The following is a description of a gene set: Genes predicted to be targets of miRBase v22 microRNA mmu_miR_1906 in miRDB v6.0 with MirTarget v4 prediction scores > 80 (high confidence targets). studied in species Mus musculus Mouse Gene Set: MIR_1906 from publication Chen Y, Wang X (PMID 31504780), and this is the list of marker genes: Apba1, Tacc1, Slc15a4, Tll1 (NCBI Gene Id 21892), Pou3f3 (POU domain, class 3, transcription factor 3), Slc22a23, Ino80d, Phf5a (PHD finger protein 5A), Wap, Zcchc2, Wdtc1 (NCBI Gene Id 277762), Fkbp5, Cdc42, Ppp1r3f, Vipr2, Dennd6a, Nf2, Eif4b, Tspan9, Chic1, Dpp9, Nacc2, Gpat4, Znrf3, Ralgps1, Ptpn4, Tmem241, Esrrg, Pappa, Ccnyl1, Gns, Zfp609, Ptprj, Cacna2d1, Adgrl2, Aoc3, Ssx2ip, Rasgef1b, Znrf2, Luzp1, Cd8b1 (CD8 subunit beta 1), Myt1l, Socs7, Slc45a4, Exoc6b, Pi15, Idh3a, Fam168b, Faf2, Ppm1k, Ankrd13d, Nphs2, Sbno1, Map3k4, Cobll1, Tcaim, Dmtn, Cc2d1b (coiled-coil and C2 domain containing 1B), Lurap1l, Lhfpl4, Mthfd1l, Zfp687, Wnk1, Strbp, Arel1, Zfp592, Ppp1r2, Peli3, Ankfy1, Fbxo9, Vegfa, P2rx6, Kif1b, Kmt5a, Ezh1, Nuak2, Ubxn7, Dcaf12l1, Crtac1, Csnk1g3, Plxna2, Tmem87a, Gpc6, Pak2 (p21 (RAC1) activated kinase 2), Plcxd2, Smg5, Pdlim1, Dhdds, Abcf1, Zdhhc8, Ccser2, Hdgfl3, Pak3, Clic5, Tnrc6b, Pacsin2, Drd1 (dopamine receptor D1), Hcfc1, Dhx58, Cpeb2, Zbtb43, Tmem41a, Otx1, Cab39, Ppp2r5a, Klf4, Krt90, Crocc2, Ciita, Litaf, Nufip2, Nktr, Cdk17, Zbtb10, Prr14l, Osbpl6, Rab1b, Cadps2, Hira, Kif21b (NCBI Gene Id 320287), Lrrfip2, Pola1, Actg1, Has2, Dcaf7, Pfpl, Ikbkb, Pkdcc, Ubfd1, Bmpr1a, Map3k7, Brsk2, Ccser1, Clip1, Tfap2a, Meox2, Scaf8, Icmt, Ppp4r3b, Spsb4, Apln, Spg21, Arhgap5, Kcnh8, Frmpd1, Zhx1, Swsap1, Tsbp1, Fam98a, Ubap1, Slc4a8, Cacna1c, Akap11, Cpeb3, Esrra, Dpy19l3, Ranbp3 (RAN binding protein 3, NCBI Gene Id 71810), Twf1, Bag5, Pdia6, Adgrb3, Cd109, Exd2, Cfap45, Ccnjl, Ap2a1, Sun2, Fbxo21, Ahcyl2, Nav1, Cdadc1, Jade2, Sec24b, Scn2a, Slitrk1, D2hgdh, Klc1, Sdf2, Sptan1, Nr6a1, Fkbp1a, Dtnb, Acsl1, Sppl2b, Pi4k2a, Jakmip2, Safb2 (scaffold attachment factor B2), Agfg1, Pnpla6, Tbkbp1, Cluh, Sting1, Chd2, 4930503E14Rik, Plpp1, Klf14, Eif4g2, Il17d, Zfp882, Fstl4, Klhl18, Armc1, Mmp19 (NCBI Gene Id 58223), Trmt61a, Hcls1, Med1, Tmem150a, Mpc1, Ube2v1, Ppp6r2, Rapgefl1, Armcx6 (armadillo repeat containing, X-linked 6), Rnf38, Fsd1, Egln2, Lamc1, Ssrp1, Elavl3, Crtc3, Chd1, Naa20, Tmem245, Angel1, Pank2, Dolpp1, Cep85, Eif4a2, Tmem98, Mllt10, Rc3h1, Dgcr2, Tigd5, Selenoi, Adissp, Zyx, Raf1, Gga3, Cbx6, Ddi2, Cdk6, Dstn, Smad3, Treml1, Kif5b, Gm2663, Vav2, Kpna4, Thbs2, Synrg, Ccdc38, Fibcd1, Tab2, Itpr1, Rab7b, Adap1, Gm5622, Syna, Rab4b, Trmt44, Atg13, Gle1, Rarb, Cmtm7, G3bp2, Kansl1l, Lrrc4c, Galnt7, Taok3, Naa15, Hars2 (NCBI Gene Id 70791), Prkcd, Golga1, Spry4, Arid4a, Aasdhppt, Chac1, Chmp7 (charged multivesicular body protein 7), Atxn1l, Ski, Slc35f6, Bcl11a, Scimp, Tubb5, Pilra, Tbcel, Lctl (NCBI Gene Id 235435), Trim66 (NCBI Gene Id 330627), Rpl22, Atp10b, Pim1, En2, Kctd1, H2ab3, Tagln3, Adgrl1, Acox1, Nup98, Arfgap2, Ctnnd1, Hectd4, Mapkap1, Arl2, Caskin1, Eif1ad, Ahsa2, Ppme1, Traf3 (TNF receptor-associated factor 3), Ccl1, Nfatc3, Zdhhc9, Szrd1, Ube2r2, Tead1, Safb, Camkk1, Prkce, Cops2, Tmem243, Bach2, Mtif3, Cnih2 (NCBI Gene Id 12794), Sf1 (splicing factor 1), Bpifa5 (BPI fold containing family A, member 5)